The following is a description of a gene set: studied in species Mus musculus from publication Chen Y, Wang X (PMID 31504780) Genes predicted to be targets of miRBase v22 microRNA mmu_miR_7078_3p in miRDB v6.0 with MirTarget v4 prediction scores > 80 (high confidence targets). Mouse Gene Set: MIR_7078_3P, and this is the list of marker genes: Nrarp, Defb1, Zfp605, Ikbip, Pdcd6ip, Col5a2, Zfx, Cald1, Rb1, Pals1, Flrt2, Epg5, Ccdc88a, Lpp, Gabrb2, Pgrmc1, Gtf2a1, Cyp2j9, Kcnh5, Tceal3, Pias1, Myt1, Arf2, Pkmyt1, Jtb, Sae1, Pex3, Zfp644 (zinc finger protein 644), Itgb1bp1, Rufy2, Krt6b, Anxa10, Hars2, Ppp2r3d (protein phosphatase 2 (formerly 2A), regulatory subunit B'', delta), Unc5c, Dlk1, Fmo2, Acmsd, Dnaaf6, Mtch2, Fbxo11, Snai2, Cep15, Bmal2, Far1, Spred1, Zfp654, Suco, Edem1, AI593442, Lmbrd1, Pptc7, Ccn3, Nudt4, Gsk3b, Ogt (NCBI Gene Id 77137), Zfp563, Prrc2b, Nat8f7, Ikzf5, Nin, Sfrp5, Phip, Nufip2, Rbmyf9 (RNA binding motif protein Y-linked family member 9), Cdca4 (NCBI Gene Id 71963), Dock4, Adprm, Tenm2, Rnf19a, Mab21l2, Rabgap1l, Paics, Tmed5, Gucy2f, Ddx3x (NCBI Gene Id 236681), Olfm3, Prl2c2, Isl1, Ppm1e, Itsn2, Wnt3, Mier3, Skint11, Etv3, Impa1, Trim23, Mat2b, Trpc6, Snx10 (sorting nexin 10), Gm14295, Cnot4, Nck2, Ankrd34b, Otud4, Akap13, Map3k5, St8sia3, Kmt5a, Gdpgp1, Nrxn1, Cab39l, Bank1, Sox14, Hnrnpc, Yaf2, Rfx4, Irx5, Plaat3, Rreb1, Kmt5b, Eif5, Ablim2, Crebzf, Tmem248, Wwtr1, Rbm41, Recql, Usp15, Capza2, Zfp148, Hnrnpr, Atad2b, Kdm6a, Slc5a8, Tra2b, Smad5, Arfgef2, Myct1, Meis2, Tspan13, Prr3, C2cd5, Apbb2, Gdap1, Ctbp2, Tnfsfm13, Cdkl5, Zcchc12 (NCBI Gene Id 72693), Ptgr3, Nudt2, Zcchc24, Fsd1l, Ing3, Selenos, Slitrk6, Sp4, Rfx3, Rbmxl2, Mtmr6, Gadd45b, Nr2e1, Hfm1, Cox16, Mfsd1, Bcl9l, Ewsr1, Cdnf, Lrrc34, Gfpt1, Zc3h6, Lats1, Ddx3y, Sec24a, Sowahb, Gprc5c, Atp6v1g1, Trpc5, Cep72, Slc30a6, Tceanc2, Slc22a3, Fut9, Casz1, Timm8b, Tbccd1, Sh3gl1, Ddx50, Cacybp, Cryba1, Zwint, Elmod2, Emp1, Dcaf5, Abcd2, Slc38a9, Rbmy, Tcf12, Plxna2 (plexin A2), Maml3, Lrrc4c, Krtap9-3, Dbx1, Numb, Kif2a, Klhl13, Tyr, Fyn, Luc7l3, Dhx9, Eif2s3y (NCBI Gene Id 26908), Erp29, Tsr2, Ppp2r5c, Napg, Hook3 (NCBI Gene Id 76095), Frmd7, Scai, Nfat5, Tmem168, Rnd3 (Rho family GTPase 3), Brcc3, Srsf10, Ncam2, Csnk1g3, Adtrp, Sgce, Rp1, Zik1, Myo5a, Pcdh19, Alg11, Pigc, Chsy1, Bltp3b, Zfp182, Entrep2, Ehmt1, Nat8f3, Abi3bp, Pgam1, Arid4b, Cers6, Scrn3, Kcnb1, Bicd1, Edem3, Klhl29, Radx, Ppargc1b, Gabpa (NCBI Gene Id 14390), Bves, Fzd8, Rnf14, Qki, Atrn, Tstd1, Mbd4, Eif4g3, Suv39h2, Bicral, Pcdhb3, Zyg11b, Mindy2, Chd1, Rbmyf8, Ccdc43, H3f3b, Ptpn12, Cavin2, Usp16 (ubiquitin specific peptidase 16), C1ql3, Setbp1, Araf, Gsdmc3, Rbmyf5, Maoa, Phf2, Mphosph9, Plcd3, Lingo1, Cdh8, Acad8, Smc3, Tram1, Kirrel1, Zfp827, Cisd2, Fndc3a, Gab3, Camk4, Hif1a, Nfia, Npr3, Dcaf10, Mmp13, Smarcb1, Smpd3, Skp1 (NCBI Gene Id 76591), Arfrp1, Zcchc4, Gopc, Raph1, Itga7, Tmem185b, Fbxo4, Phc3, Rrp1b, Fbxo28, Stt3b, Rab36, Btg3, Kcnc2, Nr3c1, Dmd, Fbxo30, Selenot, Rgs7, Dkc1 (dyskeratosis congenita 1, dyskerin), Jph4, Prl5a1, Rbms3 (NCBI Gene Id 71506), Rere, Sipa1l1, Myo1b, Zfp592 (NCBI Gene Id 330576), Pawr, Sema4d, Kctd12b, Map2, Dcp1b, Kcmf1, Zeb2, Cadm2, Rnf180, Ccl25, Sypl1, Lin9, Msl2, Jkamp, Sp3, Bcl2l13, Tshz1, Adam5, Zscan22, Arl5a, Rbmx, Pias4, Zbtb10 (NCBI Gene Id 99802), Yy1, L3hypdh, Rnf145, Actn1, Stxbp5, Bmp2k, Mcrs1, Fgd4, Rwdd4a (RWD domain containing 4A), Abcg1, Zfp367, Lrrc4b, Cnr1 (NCBI Gene Id 12801), Scn2a, Ptprg, Prl2c3, Mbnl2, Serinc5, Arid4a, Smtnl2, Agmo, Rab11fip2, Tcf4, Procr, Nat8f6, Ikzf2, Has2, Nhlh2, Stk17b, Kcna5, Cops7b, Eif2ak2, Tcf24, Ttbk2, Serpini1, Lss, Acvr1c, Ppp2r5e, Ermn, Serpinb7, Aph1c, Arhgap28, Mctp2, Ubr2, Kctd19, Gdf10, Nudcd1, Abhd13, Tnk1, Utp18, Ogn, Rbm43, Uevld, Shisa6, Fbxl3, Nfib, Rab9b, Garin1b, Zfp516, Cipc (CLOCK interacting protein, circadian), Pi4k2b, Gm15455, Usp25, Phtf2, Foxk2, Ppp1r2, Psmd3 (proteasome (prosome, macropain) 26S subunit, non-ATPase, 3), A2ml1, Tmem200c, Fmr1, Tfap2a, Tm9sf3, Rgs17 (NCBI Gene Id 80505), Mgat2, Sparc, Tbc1d12, Kpnb1, Polr1b, Tspan8, Tnfsf13, Efr3a, Nrg2, Ppp4r3b, Fzd3, Plagl2, Rictor, Fam210a, Tmod3, Ube2v1, Gpr101, Igf2bp3